Given this list of marker genes P2RY11, MT-TS2, GRN, TRRAP, CHMP2B, KCNN2, CHRNA4, MYORG, TTC19, USP8, CHD2, CPOX, NPAP1, DEPDC5, HMBS, SIM1 (SIM bHLH transcription factor 1), PARK7, CUX2, CRH, SLC7A7, MT-ND5, NPC2, PAK3, MAGEL2, CBS, MT-CO2, NAGS, ACADS, HCRT, SPP1, ZFYVE26, SRCAP, CTSH, MED12, GABRB3, JARID2, RPS6KA3, ALDH4A1 (NCBI Gene Id 8659), CACNA1A, FRRS1L, EIF3F, ALDH5A1, NR3C1, MT-TH, MT-TW, MT-TF, ATP7B, FIG4, CHRNA2, USP48, SLC6A19, MT-ND6, PSEN1, TREM2, BRAF, FCGR2A, PDGFRB, UPF3B, TBC1D7, FCGR2B, ZNF365, MT-ND4, PRORP, NDP, TWNK, SLC25A13, PIDD1, GSS, MT-TL1, MT-CO3, SLC12A6, MAPK10, ASL, HLA-DQB1, GNAS, SQSTM1, VPS13A, ATXN7, ATP13A2, ZMYM2, MT-TQ, SNORD115-1, MKRN3 (makorin ring finger protein 3), ATRX, EHMT1, DNM1, DNASE1, TNFSF4, PDE11A, PTPN22, ZDHHC9, PAH, CABP4, PWRN1, GRIN2A, ARMC5, PANK2, PRDM8 (NCBI Gene Id 56978), HERC2, CHD8, WARS2, SNORD118 (NCBI Gene Id 727676), EPM2A, PWAR1, SOBP, SAT1, SCN1A, MTHFR, MT-CO1, CHRNB2, MECP2, ITM2B, KDM1A, CLTRN, DNMT1, TP53, SNORD116-1, CLN3, MOG (myelin oligodendrocyte glycoprotein), NPC1, PUS3, NAA60, WFS1, AARS2, HLA-DRB1, MAPT, CTLA4, OCA2, ABCD1, MMACHC (NCBI Gene Id 25974), CDH23, MT-ND1, IRAK1, PRNP, DCAF17, FTL, SPART, NDN, PITRM1 (pitrilysin metallopeptidase 1), H4C3, SLC20A2, ALDH18A1, TMEM106B, PRKAR1A, NOTCH3, AIP, PPOX, TPM2, TREX1, STAT4, SPG11, KCNT1, PDGFB, VCP, BRD4, PCDH19, GCLC, SMAD4, SNRPN (small nuclear ribonucleoprotein polypeptide N, NCBI Gene Id 6638), here is a description of the gene set: Human Gene Set: HP_ABNORMAL_PSYCHOTIC_PATTERN studied in species Homo sapiens Abnormal psychotic pattern Any abnormal pattern of psychotic experiences, where an individual has significant disturbances in their thoughts, perceptions, emotions, and behavior, resulting in a loss of touch with reality.